Given this list of marker genes B3gnt6, B4galnt4, Mgat4c, C1galt1, B4galt7, Mgat5b (NCBI Gene Id 268510), Gcnt1, Mgat5, Mgat3, B3gnt3, C1galt1c1, Mgat2, Mgat4a, B3galt6, Mgat1, Gcnt3, Mgat4b, Abo (ABO, alpha 1-3-N-acetylgalactosaminyltransferase and alpha 1-3-galactosyltransferase), B4galnt3, Fut8, Gcnt4, Pomgnt1, here is a description of the gene set: Catalysis of a biochemical reaction in which one of the substrates is a glycoprotein. species: Mus musculus Mouse Gene Set: GOMF_CATALYTIC_ACTIVITY_ACTING_ON_A_GLYCOPROTEIN